The following is a description of a gene set: The series of molecular signals initiated by the cross-linking of an antigen receptor on a B or T cell. species: Mus musculus Mouse Gene Set: GOBP_ANTIGEN_RECEPTOR_MEDIATED_SIGNALING_PATHWAY, and this is the list of marker genes: Zfp683, Lat2, Skint8, Themis3, Dusp22, Cacnb4, Nfkb1, Lyn, Carmil2, Eif2b2, Sh2d1a, Icosl, Eif2b5, Usp9x, Ptpn6, Pvrig, Cd19, Thy1, Cd2ap, Gps2, Sppl3, Bax, Cd247, Rbck1, Abl1, Card11, Tec, Ctla4, Btn1a1, Lax1, Prkch, Syk, Slc39a6, Cd79a, Fcrl5, Fyb1, Mapk1, Rela, Cd79b, Ifng, Wnk1, Sos1, Cyld, Skint7, Lck, Ighe, Nckap1l, Bmx, Blk, Trav7-2, Lcp2 (lymphocyte cytosolic protein 2, NCBI Gene Id 16822), Prkd2, Stap1, Ccr7, Cmtm3 (NCBI Gene Id 68119), Skint2, Zap70, Btnl2 (NCBI Gene Id 632007), Skint1 (NCBI Gene Id 639781), Gcsam, Rnf31, Nfkbia, Sh2b2, Hras, Ptprj (NCBI Gene Id 98976), Btnl10, Cd22, Btnl6, Ceacam1, Cd300a, Cd226, Pram1, Rab29, Ermap, Itk, Lpxn, Prnp, Laptm5, Gata3, Nectin2, Slc39a10, Phpt1, Fyn, Ezr, Rps3, Braf, Blnk, Skint5, Kcnn4, Skint10, Pde4d, Klhl6, Elf1, Psen1, Crkl, Cd81, Foxp1, Eif2b3, Lipa, Ms4a1, Skint6, Dgkz, Fcmr, Itpripl1, Zc3h12a, Skint11, Plcl2, Traf6 (NCBI Gene Id 99098), Cd8b1, Skint4, Lgals3, Pde4b, Nfatc2, Ighm, Bcl10, Lime1, Fosl2, Khdrbs1, Eif2b1, Usp46, Mef2c, Cblb, Foxp3, Mog, Stoml2, Trat1, Ptprc, Stk11, Plcg2, Nras, Rftn1, Clec2i, Pawr, Txk, Fyb2, Shb, Grb2, Rc3h2, Btn2a2, Ada, Cd160, Sla2, Bcl2a1d, Cd38, Ubash3a, Fcho1, Btnl9, Rc3h1, Ptpn2, Skap1, Dennd1b, Usp12, Btnl1, Lilrb4b, Lat, Nfam1, Eif2b4, Ikbkg, Nfkbiz, Tespa1, Cd3e, Ripk2, Ube2n, Cd8a, Plcg1, Tnfrsf21, Btnl4, Vav3, Btk, Bcl2, Psen2, Skint3, Ubr2, Cd276, Vtcn1, Cacnb3, Ptpn22, Cd28, Btnl12, Nck1, Lilrb4a, Prkcb, Themis2, Plekha1, Malt1, Nfkbid, Bcar1, Skint9, Dusp3, Themis, Btrc